Given this list of marker genes CRTC2, PRKAG1, FASN, ADRA1A, RPS6KB1, ADIPOR1, GYS2, CPT1C (carnitine palmitoyltransferase 1C), ADIPOR2, TP53, PLCB1, MTOR, ACACA, STRADB, PIK3CA, CCNA1, CAB39, ELAVL1, PIK3CD, GYS1, LEP, PIK3CG, PRKACG, SLC2A4RG, SREBF1, AKT2, PIK3R1, EEF2K, CCNB1, CPT1B, RPTOR, STK11, PIK3CB, PPARGC1B, HMGCR, HNF4A, LIPE, CPT1A, SLC2A4, PIK3C3, EIF4EBP1, PRKAG3, RPS6KB2, TSC1, ADRA1B, AKT1, STRADA, CAMKK2, PRKAA1 (protein kinase AMP-activated catalytic subunit alpha 1), CAMKK1, CDKN1A, LEPR, INSR, PRKAB2, PRKAB1, PRKACB, EEF2, PRKAG2, CCNA2 (cyclin A2), PIK3R2, ACACB, PRKAA2, TSC2, INS-IGF2, PFKFB3, PIK3R3, ADIPOQ, here is a description of the gene set: Human Gene Set: WP_AMPACTIVATED_PROTEIN_KINASE_SIGNALING species: Homo sapiens AMP-activated protein kinase signaling